The following is a description of a gene set: Any process that stops, prevents, or reduces the frequency, rate, or extent of interferon-alpha production. studied in species Homo sapiens Human Gene Set: GOBP_NEGATIVE_REGULATION_OF_INTERFERON_ALPHA_PRODUCTION, and this is the list of marker genes: NMI, IL10, LILRA4, HAVCR2, PTPRS, NLRC3